Given this list of marker genes ENSG00000224090, SYNPO2, ZFPL1, IFIT3, ATP10A, GLCCI1, GAL3ST2, PLXDC1, GPR45, LILRB5, IQCF1, TNFAIP3, FEZ1, IFIT2, TGM1, GCH1, SHFL, SELENOI, GBP4, C21orf91, FGF11, OTUD1, DNAH10, OPTC, HCG4B, TMEM39A, PLEKHA4, PML, CAPS, GAS2L2, ZBTB5, PLA2G4C, ELMOD3, ADRA1B, IL6ST-DT, RBFOX2, COL7A1, SAMD9, TNF, HOXD10, RIPOR2, EXT1, DUSP5, SP140L, CLDN5, GAS1, HERC6, RIN1, CMPK2, LRP2, BCL6B, TNFSF15, SDCBP2 (syndecan binding protein 2), CALHM4, SYTL2, TLK2, IRF1, EPSTI1, ISG15, PNPT1, GCK, IFNL2, STARD5, NINJ1, IRAK2, DKKL1, CD38, NEMP1, IFNA16, DIPK1B, SLC25A28, TRIM25, CCDC146, TSPY1, PELI1, NRG1, VPS13A-AS1, OAS3, MUC5AC, DND1, TNFRSF19, ADCY10, PARP14, CAMK1G, NCDN, CLSPN, LINC01565, RYBP, WFDC5, HMCN2, CHRD, KDM6B, ASAH2B, PIDD1, RYR3, MX2, CSRP2, FAM111A (FAM111 trypsin like peptidase A), HERC5, HLA-K (major histocompatibility complex, class I, K (pseudogene)), HIVEP2, NLRC5, NEXN, SEMA6A, MIR155HG, EIF2AK3, TINCR, EDN3, GLP1R, CXCL9, CARINH, STAT2, SLAMF7, F7, AASS, RARG, PPP2R5B, RLF, KCNN1, SERPINB9P1, SEZ6 (seizure related 6 homolog), USP11 (NCBI Gene Id 8237), IDO1, TTC9B, C19orf84, DUSP16, ZSCAN12, TTC21A, ARID5A, CRYM, CSRNP1, NEURL3, COL26A1, IFIT1, MXD1, MPIG6B, DHX58, IL15RA, SBK1, ECSCR, FUZ, CDKN2A, IRF7, AIM2, RNF144A, LTA, NMRAL2P, HOXD-AS2, HES4, PLSCR1, IGF2BP1, CREB5, FBXO27, CACNA1A, OXT, PITX1, LINC00608, TMCC3, FUT9, APOL6, ATP6V1B1, IRF8, CFAP73, NIPAL4, ZC3H12C, ZNF444, ZBP1, IFI44, ARAP2, AMOTL2 (angiomotin like 2), ABTB2, PTK2B, UPK3A, XAF1, TENT4A, STK19, HILPDA, BATF2, EPOR, CERS1, NAT8B, PMAIP1, PAG1, NLRP7, DDX60, HS3ST3B1, PRKAR1B, MAML2, GYPA, GBP5, PGAP1, DYRK3, here is a description of the gene set: Genes down-regulated in comparison of control conventional dendritic cells (cDC) at 0 h versus cDCs infected with Newcastle disease virus (NDV) at 14 h. Human Gene Set: GSE18791_CTRL_VS_NEWCASTLE_VIRUS_DC_14H_DN from publication Zaslavsky E, Hershberg U, Seto J, Pham AM, Marquez S, Duke JL, Wetmur JG, Tenoever BR, Sealfon SC, Kleinstein SH (PMID 20164420) The dendritic cell (DC) is a master regulator of immune responses. Pathogenic viruses subvert normal immune function in DCs through the expression of immune antagonists. Understanding how these antagonists interact with the host immune system requires knowledge of the underlying genetic regulatory network that operates during an uninhibited antiviral response. In order to isolate and identify this network, we studied DCs infected with Newcastle Disease Virus (NDV), which is able to stimulate innate immunity and DC maturation through activation of RIG-I signaling, but lacks the ability to evade the human interferon response. To analyze this experimental model, we developed a new approach integrating genome-wide expression kinetics and time-dependent promoter analysis. We found that the genetic program underlying the antiviral cell state transition during the first 18-hours post-infection could be explained by a single regulatory network. Gene expression changes were driven by a step-wise multi-factor cascading control mechanism, where the specific transcription factors controlling expression changed over time. Within this network, most individual genes are regulated by multiple factors, indicating robustness against virus-encoded immune evasion genes. In addition to effectively recapitulating current biological knowledge, we predicted, and validated experimentally, antiviral roles for several novel transcription factors. More generally, our results show how a genetic program can be temporally controlled through a single regulatory network to achieve the large-scale genetic reprogramming characteristic of cell state transitions. studied in species Homo sapiens